The following is a description of a gene set: Genes containing one or more binding sites for (PAX7) in their promoter regions (TSS -1000,+100 bp) as identified by GTRD version 20.06 ChIP-seq harmonization. studied in species Homo sapiens from publication Yevshin I, Sharipov R, Kolmykov S, Kondrakhin Y, Kolpakov F (PMID 30445619) Human Gene Set: PAX7_TARGET_GENES, and this is the list of marker genes: RPP14, ATP11A, DMD, WDR18, CRAT, KDM5C, MRPS23, MIR9-3HG, DCN, PLA2G4D, MRPL17, BAHCC1, SRSF7 (serine and arginine rich splicing factor 7), SCN2A, RND3, RNU6-953P, UTP3, PRUNE2, FNDC3B, GIN1, PUM2, DENND4A, RNU1-19P, ENSG00000268129 (novel transcript), RNU6-1075P (RNA, U6 small nuclear 1075, pseudogene), ANKRD13A, RPS6KB2, ZNF106 (zinc finger protein 106), RPL9P21, SEPTIN9, WDR59, USP8, FAM193B-DT, EMB, TMBIM6, GASK1B, TRAPPC10, CHD7, SBNO2, TUBA1B, USP27X-DT, GIGYF2, WARS1, BUD23, ITIH4 (NCBI Gene Id 3701), GOLM2, MTND4LP21 (MT-ND4L pseudogene 21), PCBP3, LINC01871, SLC39A14, PTPA, H3-3A (H3.3 histone A), SH2B3, RNU11, NR1H2, SSC5D, ENSG00000260926, MRPL44, GP6, FCRL2, ENSG00000266976, LINC02922, PPP1CC, DDX5, LINC01719, FOXJ3, FAM210A, RASSF1, MSANTD4, KIAA0513, PRKAG2-AS2, LINC02198, TUBB4BP1, SMARCD2, LINC01588, TBCD, RIMS1, WT1, FAM91A1, BPI, TCF3, PPP2R1A, ADNP, RAB3D, SUN3, ERICH1, EVI5, LAPTM4B, CFAP299, INTS10, RNF130, SCAT2, CLPB, PUS3, MIR99AHG, SMARCE1, SPRED2, SMG7, CNIH4, FCHSD2, ATP6V1B2 (NCBI Gene Id 526), RSU1P2, EMC1-AS1, DLGAP1, KLHL14 (NCBI Gene Id 57565), SEMA6A, BBX, FASTK, TMIGD3, FAM76A, PARVB, USP17L7, ZNF600, ACAD10, FOXK2 (forkhead box K2), MXRA7, RPL32P9, NLGN1, SEL1L, ZNF195, MAPRE1P1, EVI2A, UBB, RANBP2, C12orf60, DGKI, SF3A3, CDH13, MACC1-AS1, MIR9-2HG, DNM2, MYO1E, DNAH9, BSPRY, ATAD2B, EPRS1, LINC01058, FRY, LIPC, RNU6-821P, ULK4, ADAMTS10, ADD1, CYRIB, KDM4B (lysine demethylase 4B), RNMT, RPL7L1P17, CDK12, PLD4, ATP8A1, BRF1, GASK1B-AS1, CWF19L1, CHCHD5, LINC02532, COX16, HSD17B2, CTIF, CES4A, SMG8, TPM3, AQP9, EGR2, PNLDC1, CLIP1, RNF34, HLA-DOA, RPS6KA5 (NCBI Gene Id 9252), LINC00347, HSD17B7, DHDDS, LINC00710, CAB39L, NEDD4L, WBP2, RNU6-792P, LIMA1, SMARCAL1-AS1, LINC02068, MFF, CCNG2, CRLF3P3, MEIS1, LINC02670 (NCBI Gene Id 101928298), GNPTAB, POU2F1, EIF2B3, MIR6885, VDAC1P8, SH2D4B, PTPRG-AS1, DSCAML1, KDM1A, POLDIP3, UBE2I, LINC03116, MIR3973, SEPHS1, VPS4A, DNAJC16, LINC01350, RPL5, PSMD1, ATP1A1-AS1, CIAPIN1, PTTG1IP, IQCK, AP1S2, SLC25A3, PATJ, BLM, CDC42EP3, SPATS2L, ASS1, ST3GAL5, RNU6-502P, PIPOX, FAP, TJP1, SLC4A1AP, ENSG00000229720, ARHGAP15, AOPEP, C8orf76, LINS1, SGTB, SEC22B, BICD1, ARID1A, VARS2, RNU6-531P, LINC01587, BAALC, LGI1, LINC00626, RNU6-588P, MARK3, ZNF781 (NCBI Gene Id 163115), ARHGEF10L, SPEF2, SLX4IP, RNU6-942P, MEG3, CTNND2, ACO2, CLASP1, LINC00687, NMRAL1, GNG12-AS1, UBXN2A, DHRS2, CNKSR3, TMEM160, ZNF493, DUXAP5, B3GNTL1, CTTNBP2, PRKCE, AKAP1, RNU6-365P, MALAT1 (NCBI Gene Id 378938), PSMA6P3, RPL27, WDHD1 (NCBI Gene Id 11169), ZEB2, FBXW7, CRPPA, CCDC159, PRTFDC1, FRG2LP, ARIH1, EIF2B5, HMG20A, RIPPLY2, LINC01533, HTD2, GAS7 (growth arrest specific 7), SNAI2 (snail family transcriptional repressor 2), STRC, MDH1, REV3L, GAPDHP35, DPYD-AS2, PPIP5K2, UTP15, METTL1P1, CLC, NR3C1, ZFP30, MRRF, EIF3F, ENAH, CAPN2, TAF6L, ENSG00000259039 (novel transcript, antisense to SLC35F4), RNU6-178P, TAAR3P, CAMTA1, HPS4 (HPS4 biogenesis of lysosomal organelles complex 3 subunit 2), SNORD113-9, SOCS4, EFHC1, ASMTL, MTND5P12, CDH13-AS1, ACP3, PTDSS2, ENSG00000255605, JKAMP, RNA5SP222, DHRSX, ZNF251, CRACR2B, PTPRE, ELOVL2-AS1, BTNL8, TTLL2, UBC, TMEM79, MTFR1, PIGS, EHD3, TMEM179, AMZ2, DCTN6, FANCA, GPR141, CFAP20, TCF12, INTS12, FAM83A-AS1, TRAJ30, SCGB2B2, P2RX6, CCDC59, CPNE6, LINC01237, C2CD5, RNVU1-21, FAM193B, NLRP1, NUP93, INTS5, COL18A1-AS1, EHMT1, TM9SF3, RBM47, LRRC19, KMT2A, SPOP, GEMIN6, P4HA2, NT5DC3, NATP, GRK4, CCNL1, CARMIL2, TNK2-AS1, FAM110B, PPP1R14C, ACACA, UCHL1-DT, ADAMTS5, PPP1R13B, LINC02289, RBBP8, BNC2 (basonuclin zinc finger protein 2), SZT2, PCDHAC2, CELF2, MMP27, ZNF790, LINC01619, ATAD5, SERPINB2, CYB561, LINC02960, RCBTB2P1, FHL2, B3GALNT1, TMED3, PCAT14, SNORD13, CRYL1, ZNF225, ELAVL2, GRM8, CHRNA3, MIR5087, FAM114A1, MRPS15, CD300LD-AS1, MTND4P10, FUZ, SKP2, SMG5, SLC37A4, EIF4H, SLC12A1 (solute carrier family 12 member 1), DTD2, HOXB3, MGMT, TTI2 (TELO2 interacting protein 2), SPAG4, SETX (NCBI Gene Id 85506), DNAJB6, POMGNT2, RNU6-211P, MTND3P8, TARS2, CSMD3, CALCOCO1, GALM (galactose mutarotase), WWTR1, RNU6-884P, NMD3, HK1, TUT1, MEIS3, MTF2, FLAD1, ZNF331 (NCBI Gene Id 732358), LINC01870, ITM2C, ADAD2, CUL2, DDX25, CDK5RAP1, LYRM4-AS1, CR1, ZCCHC24, MATR3, ICAM1, LINC01470, CSGALNACT2, KIF21A, B3GNT5, ID2-AS1, RNPEP, RNU6-116P, SPPL2B, OSBPL8, UBR3, ANAPC5, SGO2, RASA2, RAD51B, ARHGEF10, PAM16, NDUFS7, SPINK1, DEPDC5, RGMA, TBC1D4, GLUD1, MARCHF4, LGALS3BP, CUEDC2, NPLOC4, VEZF1 (vascular endothelial zinc finger 1), RAB3GAP2, UCHL1, ADAM10, C1orf198, SCML4, ADAM22, ARMC9, ELOBP3, RPL5P2, RNA5SP48, DMXL2, GCNT2, SF3B5, FBXL14, U2SURP, RNU6-554P, UBE2Q2P1, ADAM7-AS2, TNFRSF10B, RNU6-530P, METTL25, RBM8A, ADAMTSL5, CHN2, LINC00240, CWC22, RRAS2P2, TRMT1, ZFAND5, MGST1, CDCA2, CTBP2, DNAJC30, TNKS, PIGM, TUBD1, CRYBG2, LINC02513, TFAP2A, RAD52, LIMCH1, EIF2B5-DT, PRKAG2, ENSG00000249695, SIRT4, RPN2, IL1RN, KLHDC7B-DT, MOCS2, GALNT11, ENSG00000212144, RN7SL741P, SLC37A3, PAQR9-AS1, GTF2IRD1P1, KDSR, RNU6-757P, HMBOX1, GFUS (GDP-L-fucose synthase), MUSTN1, MIR5188, ZNF585B (NCBI Gene Id 92285), NHLRC1, SETD1A, ENSG00000261460, TTC21B, ATP5MFP7, CACYBP, SLC12A8, LINC00216, GOLGA2P5, SORT1, NDRG1, SNHG29, TTLL6, XPO5, CH25H, SNAP23, GBA1, STRA6, CA5B, CDH20, NDST4, IL4R, LPP, ATP5MG, TBC1D14, TRAJ34, MAPK4, L3HYPDH, LINC00933, CENPT, RAB11A (NCBI Gene Id 8766), SPARC, SECISBP2L, CACNA1D, UBR5-DT, CYB5R4, USP24, CPEB1, NACA4P, G2E3, BANCR, LIX1L-AS1, CTNNBL1, IGFL2, MRPL1, PKM, MOV10L1, CALM1, KCTD9, GSPT1, CORO1C, TRAPPC3, GULOP, CLASP2, LINC00570, REV1, RCOR1, INPP1, PIERCE2, SNX2, SMG7-AS1, STRN4, KCNN3, ADAM28, NDEL1, DDX18, RNU6-360P, LRRFIP2, RTTN (rotatin), HUS1, NNMT, GGA3 (NCBI Gene Id 23163), SDC2, MOCS2-DT, MIR646HG, SNX8, PTGER2, AACSP1 (NCBI Gene Id 729522), ZNF16, GGNBP2, RPL36, SMARCA2, NHP2, PPFIA3, EPB41L3, GTF2H4, WDR86-AS1 (WDR86 antisense RNA 1), RPL3P4, ZCCHC7, SLC5A10, DCTN1, ECHDC1, RNU6-752P (RNA, U6 small nuclear 752, pseudogene, NCBI Gene Id 106481417), GFOD1, CTSA, PSD3, LINC02073, RBBP5, BANP, ZNF225-AS1, SNORD49B, USP27X, NIPAL2, LRRC8B (NCBI Gene Id 23507), PEAK1, PNLIP, RNU6-628P, PGBP, ZNF517, MIA3 (NCBI Gene Id 440718), NMU, DPP9, CSTPP1 (centriolar satellite-associated tubulin polyglutamylase complex regulator 1), EGFR, KCNIP2, INTS6, TNIK (TRAF2 and NCK interacting kinase), LINC01738, ZNF827, ENSA, TIMM8BP1, DYNLRB1, SIPA1L3, ZNF385D-AS2, ANKRA2, KCTD1, NFIA, NEK7, NIN, ANXA6, SRRM1, COX7CP3, SPTBN1, FGF19, CENPU, RNU6-107P, AP2B1, ODF1, DCTN6-DT, ADAR, NDP-AS1, PHF5A, FHIP1B, RNU6-522P, C12orf76, WDPCP, PRND, GSTCD, TAX1BP1, RPL36AP17, PDP1, EEF1A1P25, ZBTB20, FAM245A, TRAF3IP2-AS1, KRT223P, LYRM4, CLEC12B, NEBL (NCBI Gene Id 51739), GRWD1, ENSG00000221345, ME2, MIR802, LINC01116, RASSF5, PDCD4, LCP2, HMOX2, RRM2B, RFC1 (NCBI Gene Id 5981), CCL4L2, HSPB3, POM121, CASC3 (CASC3 exon junction complex subunit), NRIP1, PUM1, SUGT1, CDK6, C19orf48P, MAPK8IP3, NSMAF, CPA5, TLE6, TMEM205, HTR3B, TLE4, COPS3, RNU6-1318P, NR3C2, RPL15P22, ZNF254 (NCBI Gene Id 9534), LINC01704 (long intergenic non-protein coding RNA 1704), PRKCH, PTPN4, LINC02861, BAIAP2, NEAT1, WWTR1-AS1, GATB